Given this list of marker genes SCN10A, SCN5A, NOS1AP, TBX5, KCNQ1, ANK2, CALM2, PSMB9, KCNE1, NPPA, SVIL, CACNA1C, HMGCR, CALM3, TRDN, TTR, CAV3, SNTA1, AKAP9, KCNE2, DSG2, CALM1, SCN4B, KCNJ5, KCNH2, here is a description of the gene set: Abnormal cardiac test Abnormal test result of cardiovascular physiology. species: Homo sapiens Human Gene Set: HP_ABNORMAL_CARDIAC_TEST